Given this list of marker genes F2RL2, PAK4, STAT3, PAK1, EPHB6, EPHB4, PAK6, RHOA, PIK3CA, PIK3CG, EPHB2, MMP2, PAK2, PIK3R6, PIK3R3, MMP9, KIDINS220, NGEF, PIK3CD, NGFR, NTRK2, CDH11, AKT1, TIAM1, PAK5, JUN, TRIO, PIK3R5, PIK3R4, AKT2, RAC1, TWIST1, BUB1B-PAK6, EPHB1, ARF1, PIK3CB, SORT1, MMP8, EPHB3, FOS, BDNF, PAK3, AKT3, here is a description of the gene set: Neural crest cell migration in cancer species: Homo sapiens Human Gene Set: WP_NEURAL_CREST_CELL_MIGRATION_IN_CANCER